Given this list of marker genes Mt2, Cers1, Prkn, Gpx7, Pon3, Sesn1, Prdx3, Ces1d, Tpo, Slc39a8, Lcn2, Gsto1, Kdm5c (lysine demethylase 5C), Slc30a10, Cdkn1a (cyclin dependent kinase inhibitor 1A), Aqp9, Nos3, Cd36, Mt3, Atf4, Arnt, Slc22a3, Ass1, Ahr, Gch1, Gsto2, Lyn, Gpx3, Ercc6, Scn3a, Abcc1, Kcnc1 (potassium voltage gated channel, Shaw-related subfamily, member 1), Kdm5b, Epx, Edn1, Dhrs2, Nfe2l2, Sdc1, Gstm3, Mapk1, Fmc1, Kcnc2, Adh5, Adamts13, Sod3, Slc6a1, Kdm6b, Cps1, Rab29, Txnrd2, Selenos, Rad51, Slc11a1, Lpo, S100a8, Htra2, Mtarc1, Aldh1a7, Gstm7, Esd, Ralbp1, Prkcg, Slc22a1, Kdm1a, Arnt2, Adh4, mt-Cytb, Srxn1, Dhfr, Penk (NCBI Gene Id 18619), Mb, Maob, Slco1b2, Rdh11, Slc6a14, Cp, Slc18a2, Inhbb, Mt1, Slc7a11, Apom, Gpx4, Prdx1 (NCBI Gene Id 18477), Scn9a, Col6a1, Fas, Slc22a8, Upk3bl, Aifm1, Slc23a1, Eif2ak2, Drd2, Cat, Bcl2, Gpx1, Slc47a2, Ptgs2, Fabp1, Scn11a, Oscp1, Cyp2f2, Slc22a18, Slc19a1, Nnt, Prdx6b, Lancl1, Ambp, Cyp1a1, Mapk3, Mgst2, Gsta3 (glutathione S-transferase, alpha 3), Abcb1b, Nqo1, Prxl2b, Txn1, Dhx15, S100a9 (NCBI Gene Id 99917), Oprd1, Tyms, Cdk1, Aldh1a1, Inmt (indolethylamine N-methyltransferase), Gstk1, Slc29a4, Blmh, Gabrb1, Ephx2, Trp53inp1, Htr1d, Pon1, Hp, Star, Nxn, Prdx5, Gstp1, Ccl3, Arhgap33, Park7, Hif1a, Prdx2, Prkce, Abcb1a, Ubiad1, Mtarc2, Gsta1, Atp7a, Mdm2, Fech, Slc47a1, Ppp1r9a, Ddc, Cygb, Sod1, Mt4, Ephx1, Cldn1, Apoe, Pxdn, Fos, Gpx8, Cdh13, Gpx6, Prxl2a, Nupr1, Scn1b, Slc6a4, Sesn2, Gstm6, Gucy2c, Aldh2, Gfer, Ugt1a1, Xpa, Gstm5, Abcg2, Aifm2, Gjc2, Srsf9, Slc30a3, Prdx4, Gria1, Selenot, Gata6, Scfd1, Bak1, Muc2 (mucin 2), Rps6kb1, Abtb2, Slc30a1, Scn8a, Txndc17, Mbp, Pink1, Cyp1b1, Slc30a4, Ttpa, Cnp, Apoa4, Trpm6, Pim1, Ccs, Fancc, Bax, Th, Txnrd3, Akr1a1, Mgst3, Mpo, Brip1, Kdm3b, Nr4a2 (NCBI Gene Id 18227), Aqp8, Rdh12, Pon2, Htr1b, Rab40b, Trpa1, Ednra, Dnmt3a, Selenow, Gpx5, Ccl5, Gsr, Asns, Slc22a2, Abcb6, Gpx2, Nefl, Sod2, Ehmt2 (euchromatic histone lysine N-methyltransferase 2), Ehmt1, Comt, Glyat, Abcc2, Fbln5, Ptges, Alad, Gstt1, Scn2b, Slc17a3, Tnf, Map1b, Txnrd1, Ptgs1, Prdx6, here is a description of the gene set: Any process that results in a change in state or activity of a cell or an organism (in terms of movement, secretion, enzyme production, gene expression, etc.) as a result of a toxic stimulus. species: Mus musculus Mouse Gene Set: GOBP_RESPONSE_TO_TOXIC_SUBSTANCE